Given this list of marker genes ACSL4, IL11RA, PIGL, OFD1, KRT14, DHCR7, PUF60, DYRK1A, CAMTA1, FGF3, TRPS1 (transcriptional repressor GATA binding 1), TCF12, RECQL4, AMMECR1, DYNC2LI1, NXN, MSX2, NECTIN1, MSX1, FZD2, ZFX, C2CD3, RUNX2, KCNH1, ROR2 (NCBI Gene Id 621), ATP6V1B2, CCBE1, POU4F1, EP300, RAD21, CDH11, FAT4, RPS23, DVL1, NHS, TP63, EXT1, APC, SLC37A4, ADAMTS3, BCOR, HSPG2, DDX59, WNT5A, CHD6, KCNE5, IL6ST, CBFB, KCNN3 (NCBI Gene Id 95947), IRF6, CREBBP, DVL3, here is a description of the gene set: Supernumerary tooth The presence of one or more teeth additional to the normal number. Human Gene Set: HP_SUPERNUMERARY_TOOTH species: Homo sapiens